Given this list of marker genes WNT3, WNT10A, DVL1, WNT5B, WNT1, FZD6, WNT8A, WNT6, WNT10B, WNT8B, FZD7, TCF7L2, FZD8, CCND1, FZD5, MYC, DVL2, WNT4, WNT16, WNT2, DVL3, TCF7, WNT5A, WNT9A, FRAT2, LRP6, CTNNB1, AXIN2, FZD2, TCF7L1, FZD9, WNT7A, FZD10, FZD3, AXIN1, APC, LEF1 (NCBI Gene Id 51176), WNT7B, WNT9B, WNT3A, FZD1, FRAT1, WNT2B, GSK3B, FZD4, here is a description of the gene set: LRP6-overexpression to Wnt signaling pathway. Pathway ID: N00060. Pathway type: Variant. Pathway class: nt06270 Breast cancer. Pathway Definition from KEGG: WNT -> (FZD+LRP6*) -> (DVL+FRAT) -| (GSK3B+AXIN+APC) -| CTNNB1 -> TCF/LEF => (MYC,CCND1) Human Gene Set: KEGG_MEDICUS_VARIANT_LRP6_OVEREXPRESSION_TO_WNT_SIGNALING_PATHWAY studied in species Homo sapiens